The following is a description of a gene set: Any process that activates or increases the frequency, rate or extent of signaling pathways initiated by the cross-linking of an antigen receptor on a B- or T cell. Mouse Gene Set: GOBP_POSITIVE_REGULATION_OF_ANTIGEN_RECEPTOR_MEDIATED_SIGNALING_PATHWAY studied in species Mus musculus, and this is the list of marker genes: Foxp1, Cd226, Nectin2, Lipa, Cmtm3, Cyld, Ubr2, Ada, Ptprc, Ikbkg, Kcnn4 (NCBI Gene Id 16534), Rps3, Tespa1, Cd81, Ccr7, Rela, Card11, Usp46, Nfam1, Rab29, Usp12, Slc39a10, Stap1, Prkd2, Trat1, Prkch, Bcl10